Given this list of marker genes ATIC, SHMT2, SHMT1, AMT, MTFMT, FTCD, GART, here is a description of the gene set: studied in species Homo sapiens Catalysis of the transfer of a hydroxymethyl- or formyl group from one compound (donor) to another (acceptor). Human Gene Set: GOMF_HYDROXYMETHYL_FORMYL_AND_RELATED_TRANSFERASE_ACTIVITY